The following is a description of a gene set: part of: Signaling by ERBB2 in Cancer studied in species Homo sapiens Recurrent missense mutations in regions encoding the transmembrane domain (TMD) and the juxtamembrane domain (JMD) are frequently reported in cancer. The ERBB2 TMD mutants include ERBB2 V659E, ERBB2 V659K, ERBB2 G660D, ERBB2 G660R, ERBB2 S653C, ERBB2 R677L and ERBB2 R678Q. The ERBB2 JMD mutants include ERBB2 E693K and ERBB2 Q709L. ERBB2 TMD mutants ERBB2 V659E, ERBB2 G660D and S653C (de Martino et al. 2014) are known to be activating. ERBB2 TMD/JMD mutants ERBB2 R678Q, ERBB2 E693K, and ERBB2 Q709L mutations may be activating when co-expressed with a wild type ERBB2 receptor. TMD and JMD mutations can activate ERBB2 signaling by improving the active dimer interface or by stabilizing the active conformation. TMD/JMD mutants that are activating in the presence of wild type ERBB2, such as ERBB2 R678Q, may form homodimers with the wild type ERBB2.<br><br>Based on trans-autophosphorylation of ERBB2 and its dimerization partners EGFR and ERBB3, the following ERBB2 TMD/JMD mutants are assumed to form heterodimers with EGFR and ERBB3:<br>ERBB2 S653C (de Martino et al. 2014)<br>ERBB2 R678Q.<br><br>Phosphorylation of tyrosine residues in the C-tail of ERBB2 was shown for the following ERBB2 TMD/JMD mutants:<br>ERBB2 V659E;<br>ERBB2 V659K;<br>ERBB2 G660D;<br>ERBB2 G660R;<br>ERBB2 S653C (de Martino et al. 2014 - phosphorylation at Y1248 demonstrated);<br>ERBB2 R677L;<br>ERBB2 R678Q; ERBB2 Q709L<br><br>Phosphorylation of tyrosine residues in the C-tail of EGFR was demonstrated for ERBB2 S653C (de Martino et al. 2014 - phosphorylation at Y1068) and ERBB2 R678Q.<br><br>Phosphorylation of tyrosine residues in the C-tail of ERBB3 was demonstrated for ERBB2 S653C (de Martino et al. 2014 - phosphorylation at Y1197) and ERBB2 R678Q.<br><br>Activation of downstream RAS signaling was shown for ERBB2 S653C (de Martino et al. 2014) and ERBB2 R678Q through activating tyrosine phosphorylation on ERKs (MAPK1 and MAPK3) and SHC1.<br><br>Activation of downstream PLCG1 signaling was demonstrated for ERBB2 R678Q, through activating tyrosine phosphorylation on PLCG1.<br><br>Activation of PI3K/AKT signaling by ERBB2 TMD/JMD mutants has not been tested.<br><br>Signaling by ERBB2 V659K, ERBB2 G660D, ERBB2 G660R, ERBB2 R677L, ERBB2 E693K and ERBB2 Q709L has not been sufficiently studied and they are annotated as candidates.<br><br>The following ERBB2 TMD/JMD mutants are sensitive to the therapeutic antibody trastuzumab (herceptin):<br>ERBB2 V659E;<br>ERBB2 G660D;<br>ERBB2 G660R;<br>ERBB2 R678Q;<br>ERBB2 Q709L;<br><br>With respect to pertuzumab, a therapeutic antibody that block ligand-driven heterodimerization of ERBB2, ERBB2 R678Q is sensitive to pertuzumab, while ERBB2 V659E, ERBB2 G660D, ERBB2 G660R and probably ERBB2 Q709L are resistant.<br><br>The following ERBB2 TMD/JMD mutants are sensitive to lapatinib:<br>ERBB2 S653C (de Martino et al. 2014);<br>ERBB2 R678Q;<br><br>The following ERBB2 TMD/JMD mutants are sensitive to neratinib:<br>ERBB2 V659E;<br>ERBB2 G660D;<br>ERBB2 G660R;<br>ERBB2 R678Q;<br>ERBB2 Q709L;<br><br>The following ERBB2 TMD/JMD mutants are sensitive to afatinib:<br>ERBB2 G660D;<br>ERBB2 G660R;<br>ERBB2 S653C (de Martino et al. 2014);<br>ERBB2 R678Q;<br>ERBB2 Q709L. Reactome Pathway: Signaling by ERBB2 TMD/JMD mutants, and this is the list of marker genes: ERBIN (NCBI Gene Id 55914), GRB2, NRG1, CDC37, ERBB2, EGF, ERBB3, HRAS, NRG2, NRAS, HSP90AA1, HBEGF, KRAS, NRG4, SOS1, EREG, SHC1, EGFR, NRG3, PLCG1, ERBB4, BTC